Given this list of marker genes KITLG, ADAMTS20, ADAMTS9, BCL2, ZEB2, here is a description of the gene set: Human Gene Set: GOBP_POSITIVE_REGULATION_OF_MELANOCYTE_DIFFERENTIATION Any process that activates or increases the frequency, rate or extent of melanocyte differentiation. studied in species Homo sapiens